Given this list of marker genes SRD5A3, WNT4, SRD5A1 (steroid 5 alpha-reductase 1), HSD17B3, HSD3B2, HSD3B1, CYP17A1, MED1, SRD5A2, HSD17B6, here is a description of the gene set: Human Gene Set: GOBP_ANDROGEN_BIOSYNTHETIC_PROCESS The chemical reactions and pathways resulting in the formation of androgens, C19 steroid hormones that can stimulate the development of male sexual characteristics. species: Homo sapiens